The following is a description of a gene set: Genes in the cancer module 416. species: Homo sapiens Human Gene Set: MODULE_416, and this is the list of marker genes: SAA1, TLE3, AGTR1, ADAM17, GUCA2B, EFNA1, TMF1, P3H3, SCNN1A, ADM, AQP1, CLCNKA, SLC34A1, CLCNKB, NFAT5, DUSP2, AQP3, AQP4, SLC22A4, LTF, CYP2B6, UNC13B, MAD2L1